The following is a description of a gene set: Human Gene Set: GOMF_HSP70_PROTEIN_BINDING studied in species Homo sapiens Binding to a Hsp70 protein, heat shock proteins around 70kDa in size., and this is the list of marker genes: IQCG (NCBI Gene Id 84223), HIKESHI, CREB1, BAX, DNAJB7, PPP5C, DNAJB6, TFRC, DNAJB9 (NCBI Gene Id 4189), SGTB, DNAJA4, NUP62, METTL21A, DNAJC18, NOD2, MVD, CDK1, DNAJB8 (NCBI Gene Id 165721), DNAJB14, PRKN, PPEF2, STAU2, TSC1, DNAJC8, DNAJB1, RPS3, RNF207, CYP2E1, SNCA, ST13, CYP1A1, DNAJB2, SACS, BAG6, HDAC8, DNAJA1, SPN (NCBI Gene Id 6693), DNAJC10, PPID, GPR37, PACRG, DNAJA3, STUB1, DNAJB12, DNAJC2, ERN1, FICD, DNAJA2, PGLYRP1, DNAJB3, TTC4